The following is a description of a gene set: electronically inferred by orthology from the curated human pathway studied in species Mus musculus Reactome Pathway: HSF1-dependent transactivation part of: Cellular response to heat stress This event has been computationally inferred from an event that has been demonstrated in another species.<p>The inference is based on the homology mapping from PANTHER. Briefly, reactions for which all involved PhysicalEntities (in input, output and catalyst) have a mapped orthologue/paralogue (for complexes at least 75% of components must have a mapping) are inferred to the other species., and this is the list of marker genes: Camk2b, Hsf1, Hsbp1, Dnajb1, Hspa2, Hspb8, Hspa1l, Akt1s1, Ep300, Cryab, Fkbp4